Given this list of marker genes Kit, Ghsr, Kcnma1, Ptger4, Ghrl, here is a description of the gene set: Mouse Gene Set: GOBP_REGULATION_OF_SMALL_INTESTINE_SMOOTH_MUSCLE_CONTRACTION Any process that modulates the frequency, rate or extent of small intestine smooth muscle contraction. studied in species Mus musculus